The following is a description of a gene set: The complete process of formation and maturation of an ovum or female gamete from a primordial female germ cell. Examples of this process are found in Mus musculus and Drosophila melanogaster. studied in species Homo sapiens Human Gene Set: GOBP_OOGENESIS, and this is the list of marker genes: MLH1, SOHLH2, LSM14B, ZAR1, DCAF13, MDK, MEI4, ERCC1, FOXL2, ZAR1L, TRIP13, IGF1, ZGLP1, PDE3A, BRCA2, HEXB, INHBB, SEBOX, BCAS2, NANOS2, SPDYA, FIGLA, MOS, ZP3, NANOS3, PPP2R1A, NANOS1, CDC25B, REC8, BNC1, MEIOC, SHB, METTL3, CTNNB1 (NCBI Gene Id 1499), MCMDC2, ATM, WEE2, FUT6 (fucosyltransferase 6), RBM46, H3-3A, TDRD5, SOHLH1 (NCBI Gene Id 402381), OOSP2, ANG, PTX3, TUBB8, YTHDC2, IHH, PLD6, IHO1, TDRD1, HORMAD1, MARF1, ASPM, EHMT2, MEIOSIN, TUT4, AKT1 (NCBI Gene Id 207), EDN1, NOBOX, PANX1, TDRD6, FMN2, RXFP2, AMH, RPS6KA2, FBXO5, EDNRA, DDX20, SRC, BCL2, NPM2 (nucleophosmin/nucleoplasmin 2), PAQR5, NPPC, WDR77 (WD repeat domain 77), KAT8, KASH5, EREG, YTHDF2, TAF4B, SIRT2, GDF9, WNT4, TDRKH, LGR5, WASHC5, YTHDC1, YBX2 (Y-box binding protein 2), DMC1, TDRD7, NPR2, FOXO3, C14orf39, ZNF830, PTN, PIWIL2, H3-3B, KMT2D, RAB24, PAQR7, ZFY, AURKA, SPO11, DAZL, MAJIN, TERB2, TNFAIP6, GPR149, CCNB1, BMPR1B, DIAPH2, PAQR8, REC114, TUT7, DMRT1, STRA8